The following is a description of a gene set: species: Homo sapiens Human Gene Set: GOBP_VITAMIN_B6_METABOLIC_PROCESS The chemical reactions and pathways involving any of the vitamin B6 compounds: pyridoxal, pyridoxamine and pyridoxine and the active form, pyridoxal phosphate., and this is the list of marker genes: PNPO, ALPL, PDXP, PSAT1, PLPBP, PDXK